Given this list of marker genes GRB2, IRS2, HRAS, SOS1, NRAS, IRS1, KRAS, here is a description of the gene set: Human Gene Set: REACTOME_SOS_MEDIATED_SIGNALLING species: Homo sapiens SOS-mediated signalling